The following is a description of a gene set: Human Gene Set: KEGG_MEDICUS_REFERENCE_CCR2_GNB_G_PI3K_NFKB_SIGNALING_PATHWAY CCR2-GNB/G-PI3K-NFKB signaling pathway. Pathway ID: N00399. Pathway type: Reference. Pathway class: nt06167 Human cytomegalovirus (HCMV). species: Homo sapiens Pathway Definition from KEGG: CCL2 -> CCR2 -> GNB/G -> PI3K -> PIP3 -> AKT -> IKK -> NFKBIA -> NFKB, and this is the list of marker genes: GNG2, GNG3, GNG8, GNGT1, AKT3, AKT2, PIK3CA, GNG5, GNG11, CCR2, CCL2, NFKBIA, GNGT2, RELA, GNG4, CHUK, GNB1, GNG12, PIK3CD, IKBKG, GNG13, GNG7, GNB3, GNB2, GNB4, NFKB1, PIK3CB, AKT1, GNB5, IKBKB, GNG10